Given this list of marker genes Ackr3, Phox2a (NCBI Gene Id 18934), Tfap2a, Hes3, Hes1, here is a description of the gene set: studied in species Mus musculus The process whose specific outcome is the progression of the oculomotor nerve over time, from its formation to the mature structure. This motor nerve innervates all extraocular muscles except the superior oblique and the lateral rectus muscles. The superior division supplies the levator palpebrae superioris and superior rectus muscles. The inferior division supplies the medial rectus, inferior rectus and inferior oblique muscles. This nerve also innervates the striated muscles of the eyelid. Pupillary constriction and lens movement are mediated by this nerve for near vision. In the orbit the inferior division sends branches that enter the ciliary ganglion where they form functional contacts (synapses) with the ganglion cells. The ganglion cells send nerve fibers into the back of the eye where they travel to ultimately innervate the ciliary muscle and the constrictor pupillae muscle. Mouse Gene Set: GOBP_OCULOMOTOR_NERVE_DEVELOPMENT